The following is a description of a gene set: studied in species Homo sapiens from publication He P, Lim K, Sun D, Pett JP, Jeng Q, Polanski K, Dong Z, Bolt L, Richardson L, Mamanova L, Dabrowska M, Wilbrey-Clark A, Madissoon E, Tuong ZK, Dann E, Suo C, Goh I, Yoshida M, Nikolić MZ, Janes SM, He X, Barker RA, Teichmann SA, Marioni JC, Meyer KB, Rawlins EL (PMID 36493756) Human Gene Set: HE_LIM_SUN_FETAL_LUNG_C4_NKT1_CELL NKT1, and this is the list of marker genes: RORC, BLK, TRDV2 (T cell receptor delta variable 2), CCR6, IGFBP4, CXCR6, SLC4A10, PHACTR2, IL23R